The following is a description of a gene set: An anomaly in demeanor, which refers to the outward behavior, manner, or conduct of a person. It encompasses how an individual presents themselves to others in terms of attitude, posture, and general comportment. studied in species Homo sapiens Abnormal demeanor Human Gene Set: HP_ABNORMAL_DEMEANOR, and this is the list of marker genes: HNRNPH2, OCA2, CDKL5, HNRNPC, GABBR2, SLC19A3, TBC1D23, ALG9, FOCAD, SLC18A2, NTNG1, KIF15, PSAP, ZSWIM6, SMC1A, WDR26, TASP1, ADNP, TCF4, SNRPN, HDAC8, KANSL1, IQSEC2, MECP2, FOXG1, ZEB2, ADSL, SLC9A6, SIN3A, DYRK1A, NALCN, ATP10A, RAB11B, UNC80, TBC1D2B, PSAT1, UBE3A, PRKAR1B, PHGDH, ASXL1, GRIK2, PIGS, SATB2 (NCBI Gene Id 80104), GALC